The following is a description of a gene set: Hyperextension of the metatarsal-phalangeal joint with hyperflexion of the proximal interphalangeal (PIP) joint. Human Gene Set: HP_HAMMERTOE species: Homo sapiens Hammertoe, and this is the list of marker genes: HSD17B4, FBN1, PLEKHG5, VRK1, NRCAM (NCBI Gene Id 4897), PMP22, KIF1B, MFN2, SYT2, REEP1, COA7, NDRG1, PRX (periaxin), SPTAN1, SLC35A3, NEFL, SACS, MPZ (myelin protein zero), LMNA, RAB7A, SH3TC2, BSCL2, MYH8, ADCY6, TRPV4, GDAP1, PEX7, GARS1, MAD1L1, DHCR7, HARS1, GNB4, KAT6A, PMP2, VCP, MPV17, EGR2, INF2, CHCHD10, ESCO2, MORC2, RTN2, AEBP1, ITPR3, AARS1, DCAF8, BCOR, BMPER, TOR1A, SIGMAR1, PHYH, PDXK, ESAM, CHP1, SBF2, SPART, GBF1 (golgi brefeldin A resistant guanine nucleotide exchange factor 1), LRSAM1